The following is a description of a gene set: Phosphate bond hydrolysis by NTPDase proteins Human Gene Set: REACTOME_PHOSPHATE_BOND_HYDROLYSIS_BY_NTPDASE_PROTEINS studied in species Homo sapiens, and this is the list of marker genes: ENTPD3, ENTPD6, ENTPD2, ENTPD7, ENTPD4, ENTPD8, ENTPD5, ENTPD1